Given this list of marker genes Bmal1, Ahr, Arnt2, Ncoa2, Arnt, Aip, Taf6, Taf4, Tbp, here is a description of the gene set: species: Mus musculus Binding to an aryl hydrocarbon receptor. Mouse Gene Set: GOMF_ARYL_HYDROCARBON_RECEPTOR_BINDING